Given this list of marker genes Timp3, Bst2 (bone marrow stromal cell antigen 2), Ngf, Fetub, Reck, Lxn, Spock3, Timp2, Rarres1, Spock1, Timp4, Timp1, here is a description of the gene set: species: Mus musculus Binds to and stops, prevents or reduces the activity of metalloendopeptidases, enzymes that catalyze the hydrolysis of nonterminal peptide bonds in a polypeptide chain and contain a chelated metal ion at their active sites which is essential to their catalytic activity. Mouse Gene Set: GOMF_METALLOENDOPEPTIDASE_INHIBITOR_ACTIVITY